The following is a description of a gene set: Antigen processing: Ub, ATP-independent proteasomal degradation Human Gene Set: REACTOME_ANTIGEN_PROCESSING_UB_ATP_INDEPENDENT_PROTEASOMAL_DEGRADATION species: Homo sapiens, and this is the list of marker genes: PSMB5, PSMA5, PSMB9, PSMA7, PSMB1, PSMB3 (NCBI Gene Id 5691), PSMA1, PSMA2, PSMB6, PSMA4, PSMB8, PSMB2, PSMB10, PSME2, PSMA3, PSMB4, PSME1, PSMA6, PSMB7